Given this list of marker genes Rinl, Cxcl10, Parp9, Rtp4, Mafg, Rab10, Iigp1, Atp6v0e, Plaat3, Rpia, Bcl2a1b, Tap1, Itgb7, Cxcr6, Trac (NCBI Gene Id 21474), Irf9, Ddx39b, Lgals3bp, Psmb10 (NCBI Gene Id 19171), Irgm1, Osbpl3, Tnrc6c, S100a11, Hopx, Wsb2, Tap2, Stat1, Manf, Irgm2, Agfg1, Tagln2, Zfp131, Tmbim6, Tapbp, Surf4, Nmi, Gadd45g, Psmb9, H2-T23, Furin, Samhd1, Psme1, Eef1e1, Hsp90b1, Ifngr1, Coro7, Ly6e, Serpina3g, B2m, Gbp9, Ckb, Ddx24, Kdelr1, Scfd1, Igtp, U2af1, Cd274, Phb1, Ifi203, Blk, Hspa5, Nsmce4a, Gbp8, Gbp2, Impact, Tgtp1, Dtx3l, Irf8, Tasp1, Ly6a, Maf, Rrbp1, Il12rb1, Parp14, Irf1, Bst2, Zbp1, Socs1, Ifi47, Ttc39b, Psmb8, Tapbpl, Pdia3, Gbp4 (NCBI Gene Id 17472), Sgpp1, Spcs2, Bmp7, Marchf2, Ltb4r1, Calr, Ppa1, Gbp7, Gbp6, Tmem176b, F2r, Xaf1, Psme2, Cysltr2, Parp10, Sp110, Uqcc4, here is a description of the gene set: Mouse Gene Set: CUI_T_CELL_GD_IL12_RESPONSE_UP species: Mus musculus Cytokines mediate cell-cell communication in the immune system and represent important therapeutic targets. A myriad of studies have highlighted their central role in immune function, yet we lack a global view of the cellular responses of each immune cell type to each cytokine. To address this gap, the authors created the Immune Dictionary, a compendium of single-cell transcriptomic profiles of more than 17 immune cell types in response to each of 86 cytokines (>1,400 cytokine-cell type combinations) in mouse lymph nodes in vivo. A cytokine-centric view of the dictionary revealed that most cytokines induce highly cell-type-specific responses. For example, the inflammatory cytokine interleukin-1β induces distinct gene programmes in almost every cell type. A cell-type-centric view of the dictionary identified more than 66 cytokine-driven cellular polarization states across immune cell types, including previously uncharacterized states such as an interleukin-18-induced polyfunctional natural killer cell state. Genes positively differentially expressed in cell type: γδ T cell upon treatment with cytokine: IL-12 in mouse lymph nodes in vivo. from publication Cui A, Huang T, Li S, Ma A, Pérez JL, Sander C, Keskin DB, Wu CJ, Fraenkel E, Hacohen N (PMID 38057668)